The following is a description of a gene set: species: Homo sapiens part of: Signaling by KIT in disease Mutations in the juxtamembrane region of KIT, encoded by exon 11, are especially prevalent as initiating events in gastrointestinal stromal tumors (GIST), but are also found at lower frequency in other cancers such as AML and melanoma. Mutations in this region of KIT are believed to disrupt an auto-inhibitory function, leading to constitutive enzyme activation. Unlike kinase domain mutants, juxtamembrane domain KIT mutants still undergo dimerization, although in a ligand-independent manner. Reactome Pathway: Signaling by juxtamembrane domain KIT mutants, and this is the list of marker genes: KIT